Given this list of marker genes H3C7, PLEKHM3, RNU11, MRPS31P4, ZNF791, PNISR, NUP107-DT, GIN1, UBE3B, ANKS4B, FAM228B (family with sequence similarity 228 member B), RAB18, BANF1, PPIP5K2 (diphosphoinositol pentakisphosphate kinase 2), NUP153, FANCM, LSM5, MRPS31P5, MAN2C1, NLN, ZFAND6, MPLKIP, H4C16, NDUFC2-KCTD14, CLRN3, LURAP1L-AS1, ZNF580, KCTD10, PHF14, ZNF581 (NCBI Gene Id 96067), VIPAS39, PFKM, COPS4, AHSA1, DPAGT1, ALG10, NUP107, UQCC6, EIF3F, MNAT1, ATP6V1G2, NKAPD1, MIR1245A (NCBI Gene Id 100302219), ARHGAP1, SLC39A3, PCLAF (PCNA clamp associated factor), SF3B6, TIMM29, TUT1, MRPL13, TMIGD1, USP30, HYCC2, NUBPL, ZDHHC6, MAT2B, MRPL30, MLH1, MPHOSPH10, BMS1, IQCH, GEMIN2, DCP1A, NME1, MCAT, MCEE, HEMK1, ZSCAN26, INTS5, TRIP4, RBM27, ZNF213-AS1, ATP6V1G2-DDX39B, SMG7-AS1, TXN2, ATP5PF, CSTPP1, POMP, RUVBL1, PRRG2, ZNF490, WDR24, SNORD65, CUL4A, DHRS7B, AHCYL1, VTI1A, TUBA1B-AS1, THADA, NFKBIL1, TNPO3, CCNA2, NUF2, NXT2, CDC123, MRPL1, CSDE1, UQCC1, GSTA9P, TMEM230, SNRNP27, INO80B-WBP1, H2BC9, CCDC97, ZMYND12, EPS8, ATF7IP, TMEM87A, H2BC13, YIPF2, INTS12, KIF22, TMEM222 (transmembrane protein 222), PCM1, TARS2, DMAP1, MTOR, ADPRHL1, GANC (glucosidase alpha, neutral C), RBM28, RNU7-27P, RPS7, ALG3, RPL27, ENSG00000232995, GSTCD, ENPP3, USP54, AHR, ADAP2, DSG1-AS1, NOL8, NME1-NME2, ZNF561, SNX13, SUPT7L, RN7SL382P, RNF145, ZNF205, ZC3HC1, SSPN, AAR2, VPS25, WDR83OS, GFM2, HSD17B2, LINC02453, TOR1AIP1, C2CD2L (C2CD2 like), NGRN, MTBP (NCBI Gene Id 27085), MIR17HG, MITD1, YJU2 (NCBI Gene Id 55702), NDUFB3, HDAC8, COX16, ISY1-RAB43, KIAA0586, ZNF561-AS1, TPI1P2, IPO4, LIMA1, TMEM101, PTPRO, TIMM9, RRM1, EIF5B, STX18-AS1, TAF1D, RGS5, ELP3, TMEM30A, STX18, ALDH18A1, LINC-PINT, NSL1, ENSG00000275740 (novel readthrough transcript), NOP16, GNPDA2, NR1H2, RPS18, PCID2, NDUFAF1, GABPA, RTTN, MTMR4, HIGD2A, ERCC1, UFC1, CENPP, FKBP3, ITSN2, SEC31A, BRF2, TACO1, SRSF7, BIRC2, IFT56, C12orf76, PIWIL2, SENP1, EPM2AIP1, HSPA9, TATDN3, GTPBP3, VPS52, GTF3C3, SLC4A1AP, SMG7, NOSIP, UMPS, MRPL48, NKAP, ATXN2, CALM2, NUDCD3, ISY1, SUGCT, TBC1D19, SMIM20, CFL1P1, NDUFC2, CSTF2T, CDK12, CASC2, GPAT4-AS1, TEFM, INO80B, PEMT, NUDT5, PDCD4-AS1, GPBP1L1, PSMC2, EIF1AD, GAS5, PSME2P3, TMEM128, HMGN2, MLLT3, METTL16, WDR83, FEM1B, SMG8, SLC1A3, PIH1D2, UTP3, TMEM69, ECE2, MED23, DNAJC2, ZNF165, ATF7, NSA2, SLC27A5, GOLGA3, TXNDC9, SBDSP1, ATF7-NPFF, IFTAP (NCBI Gene Id 119710), ZNF408, VPS51, MARCOL, METTL15, TTC23, CHASERR, here is a description of the gene set: Human Gene Set: RORA_TARGET_GENES species: Homo sapiens Genes containing one or more binding sites for (RORA) in their promoter regions (TSS -1000,+100 bp) as identified by GTRD version 20.06 ChIP-seq harmonization. from publication Yevshin I, Sharipov R, Kolmykov S, Kondrakhin Y, Kolpakov F (PMID 30445619)